The following is a description of a gene set: Hyperchloremic acidosis studied in species Homo sapiens Acidosis (pH less than 7.35) that develops with an increase in ionic chloride. Human Gene Set: HP_HYPERCHLOREMIC_ACIDOSIS, and this is the list of marker genes: NEUROG3, GATM (glycine amidinotransferase), CTNS, KLHL3, EHHADH, SLC4A4, GALT, NDUFAF6, WNK1, CUL3, WNK4, SLC34A1, SLC4A1